The following is a description of a gene set: Genes containing one or more binding sites for (MED16) in their promoter regions (TSS -1000,+100 bp) as identified by GTRD version 20.06 ChIP-seq harmonization. studied in species Homo sapiens from publication Yevshin I, Sharipov R, Kolmykov S, Kondrakhin Y, Kolpakov F (PMID 30445619) Human Gene Set: MED16_TARGET_GENES, and this is the list of marker genes: H1-0, VMP1, GBA1, RNU1-2, UBC (ubiquitin C), TBL1XR1, SNORD118, LINC01775, BRWD1, CHAC1, GTF2IP12, LINC00869, RNVU1-19, KMT2A, SEPTIN7P14, MALAT1, MIR5188, LINC00963, RNU5A-8P, HOXA-AS2, RNU5E-4P, RNU7-1, KDM3B, BHLHE40, LINC00431, PRECSIT, STC2, HSPE1-MOB4, ENSG00000266088, CUEDC1, C12orf57, RNVU1-30, RNVU1-25, SAMD11, RNVU1-28 (RNA, variant U1 small nuclear 28), RNU5F-1, SNORD3A, HSPE1, RNVU1-14, RHOBTB3, RCAN1, ABCC3, RNU1-1, HSPD1, TRIB3, TAGLN2, RNU5E-6P